The following is a description of a gene set: species: Mus musculus Mouse Gene Set: GOBP_POSITIVE_REGULATION_OF_CYTOSKELETON_ORGANIZATION Any process that activates or increases the frequency, rate or extent of the formation, arrangement of constituent parts, or disassembly of cytoskeletal structures., and this is the list of marker genes: Scin, Togaram1, Carmil2, Stil, Cd47, Nckap1 (NCBI Gene Id 96983), Apc, Ccl21f, Mylk3, Cfl1, Tgfbr1, Cfl2 (cofilin 2, muscle), Drg1, Ccdc15, S100a10 (S100 calcium binding protein A10 (calpactin)), Katnb1, Clip1 (NCBI Gene Id 97251), Tenm1, Braf, Cx3cl1, Edn1, Ccn2, Hspa1a, Vps4b, Fermt2, Rhoc, Nphs1, Sema5a, Pycard, Fmn1, Mlst8, Cdkn1b, Prkcq, Tgfb3, Cdc42ep2, Ccl11, Ccl21d, Pfdn2, Vasp, Mtss1, Ccl24, Bin1, Limch1 (LIM and calponin homology domains 1), Bag4, P2rx7, Rac1, Htr1a, Wnt4, Nckap1l, Kirrel1, Id1, Apoa1, Ccl21b, Mtor, Synpo2, Cenpj, Plk4, Cttn, Fer, Wasf1, Slain2, Rapgef3, Fhod1, Pdlim4, Cdc42ep5, Itgb1bp1, Actn2, Add3, Tacr1, Nck1, Pfn5, Tesk1, Nf2, Csf3, Arhgef15, Dctn1, Magel2, Arhgef5, Fchsd1, Trpv4, Prkd1, Ppm1f, Serpinf2, Cav1, Ptk2b, Epha1, Baiap2l2, Cav3, Rock2, Gsn, Gm14137, Trim27, Ccl21e, Spag5, Ppp1r35, Wmp, Slain1, Icam1, Sorbs3, Psrc1, Ep300, Stmn2, Dlg1, Limk1, Wasf3, Alox15 (NCBI Gene Id 11687), Myoc, Ccl21a, Prkce, Rps3, Gda, Swap70, Mapk8, Baiap2l1, Map1b, Ccl26, Katnbl1 (NCBI Gene Id 98995), Synpo, Tac1, Whamm, Gpsm2, Wdr1, Akap9, Spast, Map3k1, Mapk15, Hspa1b, Rhoa, Rgcc, Tpm1, Cracd (capping protein inhibiting regulator of actin), Pxn, Arl2, Dync1h1, Lpar1 (lysophosphatidic acid receptor 1), Pde4dip, Arpc2, Cyfip1, Numa1, Mapre1, Git1, Mapt, Pfn1, Pdxp, Nup62, Poc1b, Baiap2, Snx9, Arhgef10, Rictor, Nav3, Flna, Mecp2, Pak1, Cdc42ep4, Sh3pxd2b, Ppm1e, Wasf2, Sass6, F2rl1, Abi2, Cdc42ep1, Ckap5, Arhgef10l, Aurkb, Ankrd53, Plek, Lmod1, Plxna3, Met (NCBI Gene Id 194383), Kiss1r, Prox1, Nox4, Sdc4, Smad3, Myo1c, Evl, Cdc42, Brk1, Nes, Pfn2, Actr3, Fes, Pfn3, Nrp1, Vil1, Carmil1, Dstn, Ccdc88a, Wnt11, Grb2, Cdk5rap2, Synpo2l, Bmp10, Gpr65 (G-protein coupled receptor 65), Cdc42ep3, Fchsd2, Cep120, Abl1, Lmod2, Nck2, Arf6, Cep295, Tsc1 (TSC complex subunit 1)